Given this list of marker genes Sumo1, Foxl2, Mta1, Pias4, Hic1, Mitf, Trp53bp1, here is a description of the gene set: part of: SUMO E3 ligases SUMOylate target proteins Reactome Pathway: SUMOylation of transcription factors This event has been computationally inferred from an event that has been demonstrated in another species.<p>The inference is based on the homology mapping from PANTHER. Briefly, reactions for which all involved PhysicalEntities (in input, output and catalyst) have a mapped orthologue/paralogue (for complexes at least 75% of components must have a mapping) are inferred to the other species. electronically inferred by orthology from the curated human pathway studied in species Mus musculus